Given this list of marker genes TRAF6, IKBKG, TICAM1, TLR3, NFKB1, MAP3K7, NFKBIA, RELA, IKBKB, CHUK, here is a description of the gene set: Pathway Definition from KEGG: TLR3 -> TICAM1 -> TRAF6 -> TAK1 -> IKK -> NFKBIA -> NFKB studied in species Homo sapiens TLR3-NFKB signaling pathway. Pathway ID: N00563. Pathway type: Reference. Pathway class: nt06168 Herpes simplex virus 1 (HSV-1). Human Gene Set: KEGG_MEDICUS_REFERENCE_TLR3_NFKB_SIGNALING_PATHWAY